The following is a description of a gene set: The FRS family of scaffolding adaptor proteins has two members, FRS2 (also known as FRS2 alpha) and FRS3 (also known as FRS2beta or SNT-2). Activation of FGFR tyrosine kinase allows FRS proteins to become phosphorylated on tyrosine residues and then bind to the adaptor GRB2 and the tyrosine phosphatase PPTN11/SHP2. Subsequently, PPTN11 activates the RAS-MAP kinase pathway and GRB2 activates the RAS-MAP kinase, PI-3-kinase and ubiquitinations/degradation pathways by binding to SOS, GAB1 and CBL, respectively, via the SH3 domains of GRB2. FRS2 acts as a central mediator in FGF signaling mainly because it induces sustained levels of activation of ERK with ubiquitous expression.<br><br><br> part of: Downstream signaling of activated FGFR3 Reactome Pathway: FRS-mediated FGFR3 signaling studied in species Homo sapiens, and this is the list of marker genes: FRS3, FGF5, FGFR3, SOS1, FGF23, KRAS, HRAS, FRS2, FGF1, NRAS, FGF8, FGF18, FGF17, GRB2, PTPN11, FGF4, FGF9, FGF20, FGF16, FGF2